Given this list of marker genes NUP54, NUP62, LONP1, GFM1, CPT2, ADAR, PDHA1, MT-ATP6, here is a description of the gene set: Basal ganglia cysts studied in species Homo sapiens Human Gene Set: HP_BASAL_GANGLIA_CYSTS